The following is a description of a gene set: Human Gene Set: GOMF_COPPER_CHAPERONE_ACTIVITY Directly binding to and delivering copper ions to a target protein. species: Homo sapiens, and this is the list of marker genes: PARK7, CCS, ATOX1, ATP7A, COX17, SCO1, SCO2